Given this list of marker genes ZRSR2, U2AF1, SLU7, U2AF2, ZRSR2P1, U2AF1L4, here is a description of the gene set: Binding to a pre-mRNA 3' splice site sequence. Human Gene Set: GOMF_PRE_MRNA_3_SPLICE_SITE_BINDING studied in species Homo sapiens